Given this list of marker genes Cntf, Slc4a7, Bcl2, Bhlhe23, Bax, Fgf2, Fasl, Bdnf, Casp6, Tmem215, here is a description of the gene set: studied in species Mus musculus Mouse Gene Set: GOBP_RETINAL_CELL_PROGRAMMED_CELL_DEATH Programmed cell death that occurs in the developing retina.